The following is a description of a gene set: Caspase-mediated cleavage of cytoskeletal proteins studied in species Homo sapiens Human Gene Set: REACTOME_CASPASE_MEDIATED_CLEAVAGE_OF_CYTOSKELETAL_PROTEINS, and this is the list of marker genes: GSN, CASP3, GAS2, PLEC, SPTAN1 (NCBI Gene Id 6709), MAPT, CASP8, CASP6, CASP7, DBNL, VIM, ADD1